The following is a description of a gene set: species: Mus musculus Mouse Gene Set: REACTOME_SLC15A4_TASL_DEPENDENT_IRF5_ACTIVATION SLC15A4:TASL-dependent IRF5 activation, and this is the list of marker genes: Tasl, Slc15a4 (solute carrier family 15, member 4), Ikbkg, Irf5, Chuk, Ikbkb